The following is a description of a gene set: Genes up-regulated in comparison of control dendritic cells (DC) at 6 h versus those stimulated with Pam3Csk4 (TLR1/2 agonist) at 6 h. from publication Amit I, Garber M, Chevrier N, Leite AP, Donner Y, Eisenhaure T, Guttman M, Grenier JK, Li W, Zuk O, Schubert LA, Birditt B, Shay T, Goren A, Zhang X, Smith Z, Deering R, McDonald RC, Cabili M, Bernstein BE, Rinn JL, Meissner A, Root DE, Hacohen N, Regev A (PMID 19729616) mouse primary BMDCs were stimulated with tlr ligands and gene expression changes were profiled on Affymetrix arrays studied in species Homo sapiens Human Gene Set: GSE17721_CTRL_VS_PAM3CSK4_6H_BMDC_UP, and this is the list of marker genes: FANCG, XPR1, MRPL28, CCNB2, DAB2, PRPS2, MOCS2, GUCA1A, ELOVL6, IMPA2, ABHD15, ISOC1, CD93, DERL3, MRPL23, JCHAIN, PHAX, KIAA0930, TNFRSF21, SLC12A8, TMEM79, ORMDL3, MKNK2, CDKN2C, EPSTI1, CDK5, C11orf68, FCGR1A, FAU, BTK, TTYH2, SLC25A11, TTC5, NFIL3, NCOR1, CTNS, MRPS24, ARL10, CROT, CCR2, SLC40A1, MDH1, ABCB7, FAM32A, SSBP2, C19orf48P (chromosome 19 open reading frame 48, pseudogene), GSX1, MINDY1, ASF1B, STARD3, ELP2, TRAPPC14, SELENBP1, ZNF790, BPHL, SMOX, B3GNT3, HPCAL1, DMAC1, EHHADH, HEXIM1, TF, RPS14, C14orf119, USP20 (NCBI Gene Id 10868), SFXN3, POLR3GL, SASH3, PGD, CARHSP1, NAGK, GAB3, CRX, DGLUCY, FBXO25, MANBA, CST5, LEPROT, G3BP2, MRPL14, RETREG1, NME7, ELOF1, SERPINI1, RPS15A, CTDSP1, LCMT1, ENPP1, CD48, NEK7, TRIM25, MCEE, DHX58, LCLAT1, KLHL24, SIRT3, MMD, MGAT5 (NCBI Gene Id 4249), FAF1, PRKAG1, ERGIC3, CD99L2, XIRP1, IMP3, RASSF5, TGFBR1, HMGCS1, GNE, MDP1 (NCBI Gene Id 145553), MRPL49, CLEC4G (NCBI Gene Id 339390), IFT172, CDIP1, SMC3, SLC50A1, MYL12B, JPH2, ERCC6L, ADSS1, LAP3, PARP3, SLC25A35, TEC, MOCOS, UBXN1, CILK1, ENTPD1, LZTS2, PNRC1, CD28, BTBD1, TAF9, KIF9, F11R, HMGCL, FAM50A, HPGD, MED23, TMEM203, NUCB1, LAPTM4B, ATF6, ATP6V1C2, PML, FRMD4B, ACADVL, SELENOP (NCBI Gene Id 6414), ZNFX1, SNHG8, VIPAS39, TPK1, MLLT10, VEGFC, DNMBP, ITM2B, MIDN, TMUB2, CUTA, TNRC6A, GLMP, PHPT1, RPAP1, HCFC1R1, B3GNT8, TM9SF1, PISD, FAM117A (family with sequence similarity 117 member A), RPL31, HTATIP2 (NCBI Gene Id 10553), EEF1B2, RUFY3, DNAJB1, RFC1, SKP1, RGS19, TMEM140, SLC29A3, ITM2C, LDLRAP1, NCKIPSD, DBR1, CCR6, C1orf54, FAM149B1, PRXL2C, AURKA, TMEM51 (NCBI Gene Id 55092), CATSPERG, TIMM10B, SPTLC1, ARHGAP39, GSTO1, GABRB1, RGS10, PTPN18, HACL1, CCNG1, NATD1, TXN2, USP3